The following is a description of a gene set: Human Gene Set: REACTOME_DEFECTIVE_INTRINSIC_PATHWAY_FOR_APOPTOSIS species: Homo sapiens Defective Intrinsic Pathway for Apoptosis, and this is the list of marker genes: LMNB1, CDC25A, CDC25C, CDC25B, CDKN2A, APP, CDK5R1 (NCBI Gene Id 8851), GOLGA2, PRDX1, CAPNS1, LMNA, TP53, CAPNS2, C1QBP, CAPN1, CDK5, SOD2 (NCBI Gene Id 79099), FASLG, YWHAE, PRDX2, BCL2L11, FOXO3, CAPN2 (NCBI Gene Id 824), JUN, CAST